Given this list of marker genes Cope, Ccdc88a, Tmem199, Kdelr3, Copz2, Smn1, Pacs1, Tmed2, Sec22b, Kdelr2, Pacsin1, Copg1, Ccdc115, Cideb, Copa, Copg2, Arcn1, Dipk2a, Tmed10, Gnas, Bnip1, Kdelr1, Tmed3, Use1, Arf1, Scyl1, Copb1, Copz1, Golga5, Actr1a, Copb2 (NCBI Gene Id 50797), here is a description of the gene set: studied in species Mus musculus A vesicle with a coat formed of the COPI coat complex proteins. COPI-coated vesicles are found associated with Golgi membranes at steady state, are involved in Golgi to endoplasmic reticulum (retrograde) vesicle transport, and possibly also in intra-Golgi transport. Mouse Gene Set: GOCC_COPI_COATED_VESICLE